Given this list of marker genes RTL1, METTL27, VPS37D, RRAS, ODAD1, ZEB2, GPC6, LTBP1, POLR1A, NKX2-6, ELN, CLCN7, BCL11B, ALDH18A1, CBL, IFT43, ARHGAP31, NAA10, WRN, EFEMP2, EIF4H, PPP1CB, GATA4, POLA1 (NCBI Gene Id 5422), SLC2A10, BCOR, LZTR1, TNFSF11, WNT4, PIGO (NCBI Gene Id 84720), MEG3, NRAS, SKIC3, FGFR1, BAZ1B, STX1A, SPRED2, NKX2-5, DNAJC30, LIMK1, FBLN5, LTBP4, FOXF1, CLIP2, PIGN, UBE2A, ARSL, MRAS, SKIC2, KRAS, GTF2I, RIT1, DEPDC5, RFC2, TBL2, CNTN1, RAF1, TMEM270, MED12 (mediator complex subunit 12), PLXND1, CEP295, TBX1, NCF1, GTF2IRD1, BUD23, SOS2, MLXIPL, RPL10, SNX10, GTF2IRD2, PTPN11, RRAS2, FKBP6, CCNQ, MGP, DLK1, TCIRG1, GATA6, SOS1, TAOK1, JAG1, RASA2, NOTCH2, PIGL, here is a description of the gene set: species: Homo sapiens Human Gene Set: HP_PULMONARY_ARTERY_STENOSIS Pulmonary artery stenosis An abnormal narrowing or constriction of the pulmonary artery, in the main pulmonary artery and/or in the left or right pulmonary artery branches.